Given this list of marker genes DCAF7, CRIPT, PTBP3, NECTIN3, ARHGAP28, SKP1, ORC5, AMER2, EPM2A, SIL1, RAB23, PLS3, TET3, PPTC7, MAPK14, OPRPN, RAB11A, CUL3, DIP2C, ROBO2, KLHL12, ELAVL4, MECP2, KCNK10, CHTOP, MICALL1, ASPHD2, CHD6, ELOVL3, LILRA1 (NCBI Gene Id 11024), LDLRAD3, ZFR, HID1, PCDHB12, MCOLN3, PCDHB7, OTX2, CHD7, SVIL, FAM47E-STBD1, RANBP17 (NCBI Gene Id 64901), SLC7A11, IGDCC4, RXRA, LTV1, SLC13A5, ADGRL3, SHTN1, ABHD15 (NCBI Gene Id 116236), RYR2, ATG4C, MRTFB, PLOD2, PTPRE, LAPTM5, MORF4L1, MAP2, N4BP2L1, TRIAP1, SORT1, FBXW7, VAPB, SV2B, ASPH, SPATS2L, TRIO, INPP4B, KRTAP4-4, TSEN2, PAK1, GRIP1, VIPAS39, SPCS1, ZNF609, TNFRSF11B (TNF receptor superfamily member 11b), OSBPL11, MINAR1, NTNG1, MAP3K9, ATP1A2, ZXDB, SEC22A, ATG14, PRKAG2, STBD1, CRIM1, PLXNA4, GIPC3, HECTD4, USP5, TSC22D3, UGT2B10, ARNT2, TK2, MAK, LIN7A, RHBDD1, MID1IP1, NEK2 (NIMA related kinase 2), SIPA1L2, SULT2A1, PRKG1, PDGFC, KCNMA1, TBL1XR1, RPRD1B, TMEM168, COL4A3, PDIA4, NAT8L, RAP1A, ARFGEF1, DCAF16, TOR1B, SCFD2, THAP10, DGAT2, CREBRF, YY1, GALE, SKIL, DIRAS2, TFAM, PIAS1, ANK1, TSPYL5, SHISAL1, INAVA, NAA15, ADAT2, KLRC2, GOLPH3, HS3ST5, ADAM12, HEG1, ERI1, TDRD7, PPP3CA, TPGS2, TNRC6A, SPAG11B, ERAP1 (endoplasmic reticulum aminopeptidase 1), NGB, COMMD8, IRS2, N4BP2 (NEDD4 binding protein 2), ANTXR1, here is a description of the gene set: Human Gene Set: MIR6501_3P from publication Chen Y, Wang X (PMID 31504780) studied in species Homo sapiens Genes predicted to be targets of miRBase v22 microRNA hsa-miR-6501-3p in miRDB v6.0 with MirTarget v4 prediction scores > 80 (high confidence targets).